The following is a description of a gene set: Human Gene Set: HP_NEONATAL_ONSET Onset of signs or symptoms of disease within the first 28 days of life. Neonatal onset species: Homo sapiens, and this is the list of marker genes: TMEM240, NDUFS6, ST3GAL5, PPP2CA, TPI1, OTX2, ATP6V0A1, GGCX, NSD1, ITGB2, DHX9, POMC (proopiomelanocortin), SKIC2, DNM1L, SUPT16H, PUM1 (NCBI Gene Id 9698), KCNJ13 (potassium inwardly rectifying channel subfamily J member 13), NUP133, TP73, AUTS2, LYRM4, ATP13A3, DNAAF6, TRAPPC4, AMT, C12orf57, ERCC5, DOHH, PIGU, AKR1D1, ASL, SLC38A3, KDM6A, KCNT2, DNAL1, QARS1, NDUFS8, ARHGDIA, HADHB, RPS19, KCNJ1, ACSL5, NKX2-1, SPATA7, WDR45B, TBCK, SCO2, TP53, KCNT1, GFPT1, HPD, MDH2, MAGEL2, SLC25A1, SCNN1G, MPDU1, CACNA1A, ADK, GMPPB (NCBI Gene Id 29925), CSF3R, SMN1, MRPS34, EBF3, COL12A1, CTNNB1, HLCS, CAV1, ABHD16A, SLC37A4, NDUFAF3, EPCAM, ODAD4, DBT, KCNJ11, SUOX, HR, KCNJ5, SCN4A, ATP1A1, GRIK2, PTS, OTC, LYN, TRMT10C (tRNA methyltransferase 10C, mitochondrial RNase P subunit), HCFC1, ATP6AP2, STXBP1, HYDIN, RIPOR2, ADNP, CPS1, PROS1, FGF13, CHRND, PSMB9, PPOX, ATP5PO, ITGA2B, NDUFS1, MYBPC3, COX11, ARG1, F13A1, UNC13D, STT3A, UFSP2, SLC13A5 (NCBI Gene Id 284111), HSPD1, NOS1AP, TSPYL1 (TSPY like 1), H1-4, BRAT1, SLC12A6, SOX10, CLXN, GTPBP3, PSAT1, KIF5A, POMP, NEUROG1, CHAMP1 (chromosome alignment maintaining phosphoprotein 1), LTBP3, G6PC3, RAI1, DOCK2, HSD17B4, CLCN3, NEUROG3, DGAT1, OCLN, STAG1, WWOX, HPS5, DRC1, ASS1, ARX, ATP11A, ENPP1 (ectonucleotide pyrophosphatase/phosphodiesterase 1), ARPC5, HDAC4, PRDX1, HMBS, NDUFV2, CNOT1, RIPK1, COL6A3, CLDN1, RNF31, TSHR, MOCS2, PTF1A, GRIN2D, ARL2BP (ADP ribosylation factor like GTPase 2 binding protein), PEX2, NFIX, RBL2, NR3C2, GET3, ATP1A2, TRAF7, SIN3A, EXTL3, RHAG, VARS2, FTH1, GJB2, LCT, C2orf69, GNAO1, GALT, KCNQ2, ASNS, DEPDC5, ARNT2, TJP2, STAT3 (NCBI Gene Id 6774), AP4E1, KIF14, GLUD1, SCNN1A, TMEM163, NDUFA11, KRT5, CACNA1I, HADHA, ATP6V0A4, CFAP300, LAMA3, NUDT2, MTRR, COX10, MCIDAS, MUSK, MYL2, ERF, NLRP12, ABAT, NSRP1, UGT1A1, LRPPRC, NEK8, PEX1, OTUD7A, GABRG2, ITGA3, GRIN1, BRAF, UBA1, LAT, CYP11B2, ESAM, COX15, ALDH7A1, NDUFA2, SLC25A13, DNAAF5, USP53, SLC2A10, CDC42BPB, LIPT2, FRMD5, NUP214, GCSH (glycine cleavage system protein H), RRM2B, TNFRSF11A, SPTBN4, KCNQ3, TPM1, SEC61A1, CRYAB, SLC19A1, ANK1, WASHC4, DENND5A, CRELD1, CRLS1, MINPP1, ACOX1, MMUT, TUBA1A, CARMIL2, USP18, RRAGC, AP3B2, RYR1, GLIS3, TELO2, PXDN (peroxidasin), AVPR2, XPA, ATP5F1D, STX3, OSTM1, C1QC, DCDC2, SMARCA2, NLRP3, SMARCAD1, GCDH, NPC2, ZFX, KDM5B, DIAPH1, MTR (NCBI Gene Id 4548), MRAP, CDSN, LAMB2 (laminin subunit beta 2), NFASC, ITGB3, CBS (cystathionine beta-synthase), SCN3A, CACNA1G, STS, BRPF1, KCNMA1, KRT10, ALG11, SYNJ1, PIGP, RAP1GDS1, TRNT1, OXCT1, RBCK1, CELF2, NEK10, MYO1H, SELENON, SOX11, UBE3C, TSFM, RAC1, RPGRIP1 (NCBI Gene Id 57096), NR1H4 (nuclear receptor subfamily 1 group H member 4), PKHD1, SLC2A1, BTK, PMM2, CYP11B1, IRS4, MRPL39, KIF12 (NCBI Gene Id 113220), KCNH5, TTN, RNF125, GLRB, SLC6A5, MAG, AXIN1, CYP7B1, COX4I2 (NCBI Gene Id 84701), SAMD9, SLC6A3, GLYCTK, LIAS, HCK, ATP5F1A, PROC, CIC, TRIP4, TFAM, SLC10A1, SFTPB, PSAP, NAGS, PACS2, DNAH5, NLRC4, AP4S1, GCH1, HADH, CNTN1, STIM1, HYOU1, TNNT1, KYNU, ARL13B, ADSL, KCNB1, AEBP1, PSMB10, LSS, SAMHD1, FBXL4, TRMU (NCBI Gene Id 55687), CHAT, CHRNE, AGR2, UQCC3 (ubiquinol-cytochrome c reductase complex assembly factor 3), CACNA2D2, DUT, LMNA, CHST14 (NCBI Gene Id 89881), INSR, SELENOI, POLE, GMPPA, MARS1, GUF1, RP1L1, CFAP410, LMBRD1, SNX14, ADAR, SRP54, CACNA1S, PDP1, VPS50, COQ9, PDSS2, RHOBTB2, NR0B1, PPCS, FKRP, PLXNA1 (plexin A1), COQ4, HACD1, GUCY1A1, COL6A2, SLC4A10, FARS2, ZNF142, MYO5B, TRMT5, SLC39A7, CACNA1C, FGF12, LBX1, ABCD4, IFIH1, ADA, AQP2, TDO2, CCDC78, HID1, RERE, FOCAD, PLVAP, TNFSF11 (NCBI Gene Id 8600), NDUFS2, VIPAS39, SLC25A22, CA5A, LTBP1, SLC1A2, FBP1, FOXRED1, ATP6AP1, CD320, AP1S2, PEX6, BCKDHB, SLC5A1, AMACR, DNAJC21, SLC35A2, NEDD4L, SECISBP2, TCN2, NFU1, TOR1A, RAP1B, SCN9A, VPS45, NKX6-2, PURA, VAMP1, ACTA1, CILK1, PAX8, ACY1, IL36RN, PLPBP, CD79A, TRPV4, SUCLG1, SLC51B, AGK, CALM1, SCNN1B, HNF4A, STING1, KMT2D, SERPINB7, NT5C3A, C1QBP, PCDHGC4, GALM, ANO1, VDR, NAA20, CEP120, ZBTB20, TEFM, WARS2, KCNC2, UQCC2, ABCC8, ALG12, SH3PXD2B, DNASE2, UPF3B, NHLRC2, SLC10A2, LZTR1, AHDC1, ATP1A3, AIRE, ACADVL (acyl-CoA dehydrogenase very long chain), TMEM38B, EIF3F, PPP1R21, DNAI2, NDUFA10, MMACHC, HSD3B7, AGPAT2, EEF1A2, LYST (lysosomal trafficking regulator), KRT14, FOXG1, UBA5, MPV17, RPL3L, COL7A1, POLR1A, ZNF408, GAD1, SLC2A2, GPHN, RFXAP, GALE, SCN8A, MMAB, PNLIP, ODAD1, NDUFA9, IL2RG, SHMT2, INTS11, U2AF2, COX16, MRPL3, CALM2, DCN, IL1RN, ADA2, CLPB, VPS13B, CLCN7 (NCBI Gene Id 7814), DGUOK, PHOX2B, ATP2A1, ACADS, HPDL, HTRA2